Given this list of marker genes NDUFA6, NDUFA11, NDUFC2, NDUFB7, NDUFA2, NDUFA3, NDUFC1, MT-ND6, NDUFB6, NDUFB1, NDUFB2, MT-ND5, NDUFA10, NDUFV1, NDUFS2, NDUFA13, MT-ND1, NDUFB8, NDUFB5, NDUFS7, NDUFS5, NDUFA9 (NADH:ubiquinone oxidoreductase subunit A9), NDUFV3, NDUFB4, NDUFS3 (NADH:ubiquinone oxidoreductase core subunit S3), NDUFB3, NDUFS4 (NADH:ubiquinone oxidoreductase subunit S4), NDUFAB1, NDUFA1, MT-ND2, NDUFA4, NDUFS1, MT-ND4, NDUFA5, MT-ND3, NDUFA8, NDUFB10, NDUFB9, NDUFS8, NDUFS6, NDUFB11, NDUFV2, TARDBP, NDUFA7, NDUFA12, here is a description of the gene set: Mutation-caused aberrant TDP43 to electron transfer in Complex I. Pathway ID: N01136. Pathway type: Variant. Pathway class: nt06464 Amyotrophic lateral sclerosis. Human Gene Set: KEGG_MEDICUS_VARIANT_MUTATION_CAUSED_ABERRANT_TDP43_TO_ELECTRON_TRANSFER_IN_COMPLEX_I species: Homo sapiens Pathway Definition from KEGG: TARDBP* -| CxI -> Q